Given this list of marker genes OFCC1, MBP, ITGAE, TCERG1, RPS19, SRGAP3, ZDHHC18, H2AC21, PPM1G (protein phosphatase, Mg2+/Mn2+ dependent 1G), NOP53, UBE2D2, TOPBP1, DPP4, EIF4ENIF1, TRIP13, MICAL1, PDCL3, HJV, BZW2, GPR153, ZBTB46, YBX1, ATP5F1E, GTPBP4, ALDOC, ASL, GPM6B, DAZAP1, KIF21B, DNAJC9, AURKAIP1, GRAP2, TULP3 (TUB like protein 3), KLRK1 (NCBI Gene Id 22914), H4C4, HAUS8, RPL26, OSBPL3, MRTO4, EIF3B, RPS11, SERF2, GPR82, PA2G4 (NCBI Gene Id 5036), NEDD4L, PRPF40A, SCRT2, KYNU, RRAS2, KMO, AFG2A, CHEK1, RALA, RNASEH2B, STRBP, DDX27, H1-6, MREG, TRIM59, MPZL2, CDKN3, RPSA, CLEC4G, AKT1, QPCT, CNOT6, CCDC88A, FAM149A, NOP16, EIF2S1, PRKAB2 (protein kinase AMP-activated non-catalytic subunit beta 2), ITGB7, SUV39H1, CLDN6, RIN3 (NCBI Gene Id 79952), NELFE, PUS1, WDFY4 (WDFY family member 4), CDV3, LY75, CRIP1, GLRX2, CACNB3, SINHCAF, DNTTIP1 (NCBI Gene Id 116092), MCM10, NET1, RPL12, POLR1E, TFAM, CORO2A, GTSE1, POMP, CENPQ, CTPS1, CD24, TBC1D8, MCM4, HSPA14, NHP2, ARSB, NONO, FLT3, RBM3, PLP2 (proteolipid protein 2), FGFR1OP2 (NCBI Gene Id 378428), SPC24, LSM1, RPS20, SOCS2, EDF1, KNL1, SEPTIN6, H4C14, PPM1M, TMEM198, RPS15, H2AC15, HIRIP3, MTHFD2, ERH, CCDC69, DOCK10, PPP1R11, GSTCD, GINS4, AP1S3, CKS1B, RAB4B, BRI3BP, MDH2, SYCE2, ITGAX, XCR1, HUWE1, CKB, FYN, VRK1, FFAR2, CNN2, MVB12A (multivesicular body subunit 12A), STRIP2, DDX19B, RPUSD4, LIG1, CLSPN, SSX2IP, GEN1, PRSS3, CS, BHLHE40, TMSB10, OLA1, EVI5L, TXNDC15, KLRD1, SF1, ARMCX4, EZH2, HDAC1, GPR33, S100A11, SNRPG, POLE, TBRG1, CCND3, OSTF1, KCTD1, MAP4K1 (NCBI Gene Id 11184), ASB2, here is a description of the gene set: species: Homo sapiens Genes down-regulated in cells from Flt3L Melanom injected mice: 33D1+ versus CD4 T cells. from publication Dudziak D, Kamphorst AO, Heidkamp GF, Buchholz VR, Trumpfheller C, Yamazaki S, Cheong C, Liu K, Lee HW, Park CG, Steinman RM, Nussenzweig MC (PMID 17204652) Dendritic cells (DCs) process and present self and foreign antigens to induce tolerance or immunity. In vitro models suggest that induction of immunity is controlled by regulating the presentation of antigen, but little is known about how DCs control antigen presentation in vivo. To examine antigen processing and presentation in vivo we specifically targeted antigens to the two major subsets of DCs using chimeric monoclonal antibodies. Unlike CD8+ DCs that express the cell surface protein CD205, CD8- DCs, which are positive for the 33D1 antigen, are specialized for presentation on MHC class II. This difference in antigen processing is intrinsic to the DC subsets and associated with increased expression of proteins associated with MHC processing. Human Gene Set: GSE6259_FLT3L_INDUCED_33D1_POS_DC_VS_CD4_TCELL_DN